Given this list of marker genes AQP8, SLC46A1, ABCB9, PDPN, SLC14A2, SLC15A1, SLC25A40, SLC38A3, SLC38A5, ABCC1, SLC27A1, SLC15A3, SLC25A39, ABCC5, AQP9, SLC25A47 (solute carrier family 25 member 47), SLC15A2, SLC38A9 (NCBI Gene Id 153129), AQP7B, SLC25A42, SLC13A3, SLC33A1, SLC25A17, MFSD1, ABCD1, AQP10, SLC25A32, SLC14A1, SLC19A2, SLC38A7, SLC5A6, AQP7, SLC19A1, ABCG2, SLC15A4, GJA1 (NCBI Gene Id 7953), SLC25A16, ABCC4, AQP3, ABCD2, here is a description of the gene set: Human Gene Set: GOMF_AMIDE_TRANSMEMBRANE_TRANSPORTER_ACTIVITY Enables the transfer of an amide, any compound containing one, two, or three acyl groups attached to a nitrogen atom, from one side of a membrane to the other. studied in species Homo sapiens